Given this list of marker genes SCNN1B, SCNN1G, SLC9A4, SLC9A9, SLC9A3, HCN1, SCNN1D, SLC5A2, HCN3, SLC9A2, SLC9A7 (solute carrier family 9 member A7), SLC5A6, MIR448, SLC8A1, TRPM4, SCNN1A, SLC5A1 (solute carrier family 5 member 1), HCN4, PCSK9, STK39, ASIC5, NEDD4L (NCBI Gene Id 93998), SLC9A1, SLC9C2, SLC9A6, MIR24-1 (NCBI Gene Id 407012), SLC12A2, SLC34A1, SLC6A1, HCN2, SLC9C1, SLC9A5, here is a description of the gene set: species: Homo sapiens The directed movement of sodium ions from outside of a cell, across the plasma membrane and into the cytosol. Human Gene Set: GOBP_SODIUM_ION_IMPORT_ACROSS_PLASMA_MEMBRANE